Given this list of marker genes Tasor, Plpp6 (NCBI Gene Id 74411), A130010J15Rik, Rabl3, Ube2w, Smyd4, here is a description of the gene set: Mouse Gene Set: MIR_136_3P studied in species Mus musculus Genes predicted to be targets of miRBase v22 microRNA mmu_miR_136_3p in miRDB v6.0 with MirTarget v4 prediction scores > 80 (high confidence targets). from publication Chen Y, Wang X (PMID 31504780)